Given this list of marker genes Atp1b2, Kcnq5, Fxyd6, Kcnip4, Kcnh6, Kcnk13, Atp1a2, Kcnt2, Kcna10, Slc12a6, Kcnc4, Mcoln3, Kcnmb1, Alg10b, Drd2, Kcnv1, Casq2, Kcnj16, Kcna5, Kcnq2, Kcnk9, Aqp1, Wnk2, Gal, Nalcn, Flna, Kif5b (NCBI Gene Id 16573), Fxyd4 (FXYD domain-containing ion transport regulator 4), Nedd4, Trpm5, Kcnj6, Slc24a2, Cav1, Kcnmb3, Ank2, Hpn, Sumo1, Kcnq4, Slc9a9, Atp1b4, P2rx7, Kcnn3, Atp4b, Kcnk16, Plcb4, Slc9a6, Kcnip2, Slc1a3, Kcnn2, Lrrc52, Atp1b3, Scn4a, Kcnf1, Nos1, Crbn, Rgs7, Slc9a1, Kcnma1, Oprk1, Kcnv2, Kcnab1, Agrn, Slc24a4, Kcnab2, Kcnj4, Fxyd3, Kcnb2, Nos3, Kcnq1, Cnga2, Kcnip3, Slc9a4, Kcna2, Ank3, Atp4a, Kcnb1, Kcnt1, Kcnip1, Kcna7, Kcnk10, Fxyd2, Kcne1, Slc24a5, Kcns1, Large1, Akap5, Prnp, Gck, Kcnj10, Kcnk1, Kcnq3, Kcnk4, Slc17a6, Ywhae, Kcnn4, Kcnh4, Akap6, Fxyd5, Kcnk12, Kcnh3, Cd63, Kcna3, Kcnd2, Kcnh2, Gnb2, Neto1, Kcnab3, Slc12a8, Kcnj2 (potassium inwardly-rectifying channel, subfamily J, member 2), Adcyap1, Kcnj12, Kcnj15, Kcns3, Kcnj14, Cckar, Ptk2b, Kcnrg, Kcnj9, Vip, Grp, Atf4, Lrrc55, Kcnh1, Slc9a2, Hcrt, Slc12a3, Wnk3, Dpp6, Kcnk2, Kcne2, Hcn3, Kcnk6, Kcnu1 (NCBI Gene Id 16532), Tsc1, Kcnc1, Pkd2l1, Slc24a3, Cdk2, Slc24a1, Slc12a4, Kcng4, Atp12a, Slc9c1, Fhl1, Wwp2, Bin1, Slc12a7, Hbp1, Hcn1, Wnk4, Ccdc51, Gja5, Htr2a, Kcnk3, Kcnj11, Atp1a1, Kcnh5, Slc9a7, Kcng1, Kcnc3, Abcc8, Stk39, Ghitm, Galr2, Cacna1d, Ptger3, Dlg1, Cav3, Kcnd3, Dpp10, Kcng3, Kcne5, Akap7, Abcc9, Kcnk5, Gnaq (NCBI Gene Id 71788), Actn2, P2ry12, Tmem175 (NCBI Gene Id 72392), Kcne4, Kcnj1, Slc12a1 (solute carrier family 12, member 1), Kcna1 (potassium voltage-gated channel, shaker-related subfamily, member 1), Tmco3 (NCBI Gene Id 97481), Kel, Kcnk15, Lrrc26, Atp1b1, Kcnmb4, Hcn2, Kcnh7, Kcnk7, Amigo1, Rgs4, Kcnj3, Nedd4l, Kcns2, Mcoln1, Vps4b, Kcnj8, Pkd2 (NCBI Gene Id 77380), Nsf (N-ethylmaleimide sensitive fusion protein), Vamp2, Cnga4, Kcng2, Ano6, Rnf207, Cxcl1, Kcnj5 (NCBI Gene Id 16521), Kcnd1, Slc9a5, Kcnj13, Akap9, Kcna6, Oxsr1, Kcna4, Slc9a3, Hcn4, Edn3, Kcnk18, Atp1a4, Drd3, Tmem38a, Tmem38b, Cpox, Trem2, Nppa, Abcb8, Kcne3, Kcnmb2, Letm1, Fxyd7, Cdkn1b, Fxyd1, Kcnh8, Itgb1, Slc17a7, Adrb2, Slc9a8, Kcnn1, Slc12a5, Atp1a3, Lrrc38, Snap25, Nr3c2, Kcnc2, Adora1, Slc12a2, Wnk1, here is a description of the gene set: The directed movement of potassium ions (K+) into, out of or within a cell, or between cells, by means of some agent such as a transporter or pore. Mouse Gene Set: GOBP_POTASSIUM_ION_TRANSPORT studied in species Mus musculus